The following is a description of a gene set: part of: Plasma lipoprotein assembly, remodeling, and clearance Reactome Pathway: Plasma lipoprotein assembly Because of their hydrophobicity, lipids are found in the extracellular spaces of the human body primarily in the form of lipoprotein complexes. Chylomicrons form in the small intestine and transport dietary lipids to other tissues in the body. Very low density lipoproteins (VLDL) form in the liver and transport triacylglycerol synthesized there to other tissues of the body. High density lipoprotein (HDL) particles are formed primarily by the liver and shuttle several kinds of lipids between tissues and other lipoproteins (Vance & Vance 1990). The assembly of these three classses of lipoproteins is annotated here. studied in species Homo sapiens, and this is the list of marker genes: APOB, PRKACA, MTTP, PRKACB, APOA1, P4HB, APOC2, ABCA1, APOC3, APOC4, PRKACG, APOA4, APOA2, APOC1, A2M, APOE, ZDHHC8, SAR1B, BMP1